Given this list of marker genes TRAF7, MT-ATP6, SMARCB1, PHOX2A, SUFU, SMO (NCBI Gene Id 6608), KIF21A, BAP1, BRAF, CTNNB1, PIK3CA, TUBB2B, TUBB3, AKT1, NF2, TERT, TUBA1A, COL25A1, SMARCE1, CDH23, PDGFB, here is a description of the gene set: studied in species Homo sapiens Human Gene Set: HP_ABNORMAL_VISUAL_FIELD_TEST Abnormal visual field test Abnormal result of a test designed to test an individual's central and peripheral vision by determining the ability of the individual to perceive objects at differing locations of the visual field.